Given this list of marker genes ACTR2, ARPC5, HIP1R, ARPC4, TRIM27, DNAI3, CARMIL2 (NCBI Gene Id 146206), ARPC1A, BRK1, ARPC1B, RNH1 (NCBI Gene Id 6050), ARPC2, IQGAP2, WASHC2A (NCBI Gene Id 88731), NCKAP1, ABI2, WASHC4 (WASH complex subunit 4), WASF1, WASHC5, WASHC3, WIPF3, CARMIL3, JMY, ARFIP2, MAGEL2, WHAMM (NCBI Gene Id 123720), CARMIL1, CTNNA2, CYFIP1, ACTR3, ARFIP1, ARF1, WASHC2C, ARPC3, WASF3, WASH6P, ARPC5L, GMFG, AP1AR, GMFB (glia maturation factor beta), WASH3P, WASHC1, CORO1B, FCHSD2, PICK1, WASF2, here is a description of the gene set: studied in species Homo sapiens The actin nucleation process in which actin monomers combine to form a new branch on the side of an existing actin filament; mediated by the Arp2/3 protein complex and its interaction with other proteins. Human Gene Set: GOBP_ARP2_3_COMPLEX_MEDIATED_ACTIN_NUCLEATION